The following is a description of a gene set: Human Gene Set: MIR3650 from publication Chen Y, Wang X (PMID 31504780) species: Homo sapiens Genes predicted to be targets of miRBase v22 microRNA hsa-miR-3650 in miRDB v6.0 with MirTarget v4 prediction scores > 80 (high confidence targets)., and this is the list of marker genes: STT3B, MCU, COL6A6, CTSE, PANX3, PRMT2, ZNF75A (NCBI Gene Id 7627), IFI16, STEAP2, MAGEC1, RHOQ, MAK16, NPAS4, ECM1, AP5Z1, ABR, PCF11, FGF2, PDK3, MFAP3 (microfibril associated protein 3), DNM1 (dynamin 1), APPL1, CEND1, DENND1C, C2CD6, PTCHD1 (patched domain containing 1), SRCIN1, STAG2, PLAGL2, ERICH4, TECPR2, SLC37A2, SSX7, PAPPA, KCNIP1, RHOC, LMX1A, GOLGA1, FAM240A, ANAPC10, VAMP7, STX1B, CLIP2, HS3ST3B1, NWD2, USP13, CCDC92, CREB3, TP53INP2, TMX4, RETREG1, ABO, GRIP2, TENT5A, RIOK1, MYO1D, FNDC7, BMP4, HDX, COL8A1